Given this list of marker genes CCNA1, PSMD6, PSMA6, PSMC3, UBE2E1, PSMD3 (NCBI Gene Id 94019), MAD2L1, PSMC1, PSMD14, PSMC2, PSMA1, PSMB4, PSMA2, PSMC4, CDC26, PSMB1, PSMA5, ANAPC4, CDC20, BUB1B, PSMD13, CDC16, ANAPC7, UBE2C, ANAPC16, UBB, PSMC6, ANAPC1, PSMD12, PSMB3, PSMB5, PSMB7, PSMA3, ANAPC11, CDK1, BUB3, UBE2S, CCNA2, PSMD1, PSMD11, ANAPC2, CDC27, ANAPC10, PSMA4, PSMB6, ANAPC5, PSMC5, PSMA7, NEK2, UBC, PSMD2, UBA52, ANAPC15, ADRM1 (NCBI Gene Id 11047), CDC23, PSMB2, RPS27A (ribosomal protein S27a), PSMD8, SEM1, UBE2D1 (NCBI Gene Id 9335), PSMD7, here is a description of the gene set: species: Homo sapiens part of: APC/C:Cdc20 mediated degradation of mitotic proteins APC:CDC20 mediates the degradation of a number of cell cycle proteins including Cyclin A and Nek2A. Reactome Pathway: APC:Cdc20 mediated degradation of cell cycle proteins prior to satisfation of the cell cycle checkpoint